The following is a description of a gene set: from publication Chen Y, Wang X (PMID 31504780) species: Homo sapiens Human Gene Set: MIR4433A_5P Genes predicted to be targets of miRBase v22 microRNA hsa-miR-4433a-5p in miRDB v6.0 with MirTarget v4 prediction scores > 80 (high confidence targets)., and this is the list of marker genes: CLTC, BRPF3, RNF187, IKZF1, TMEM64, RXRA, SGK1, UBR2, SLIT2, BTNL9, MAPK10, TIMM17A, AFG1L, KIF24, CD1D, GRID2, KRAS (NCBI Gene Id 3845), SYNRG, SNRPD1, LHX1, AGPAT4, AGPAT1, NEDD9, GALNT2, PTBP2, ZFP36L1, BTRC, RPL41, TIMM8A, PTPN12, TM9SF3, SP140, ATP7A, SAMD4B, ATF6B, CPN1, HOMER1, CREBZF, ARID5B, ATP9A, STRN3, PRTFDC1, ARHGEF7, CENPN, MOCS2, COX4I1 (cytochrome c oxidase subunit 4I1)